The following is a description of a gene set: species: Mus musculus Any process that modulates the frequency, rate or extent of glutamate receptor clustering. Mouse Gene Set: GOBP_REGULATION_OF_GLUTAMATE_RECEPTOR_CLUSTERING, and this is the list of marker genes: Zdhhc2, Dlg4, Shank3, Slc7a11, Frrs1l, Ssh1, Shisa7, Snx27, Shisa6, Grip2